Given this list of marker genes Slc47a1, Slc47a2, Slc22a1, Atp13a3, Slc22a2, here is a description of the gene set: species: Mus musculus Mouse Gene Set: GOMF_PUTRESCINE_TRANSMEMBRANE_TRANSPORTER_ACTIVITY Enables the transfer of putrescine from one side of a membrane to the other. Putrescine is 1,4-diaminobutane, the polyamine formed by decarboxylation of ornithine and the metabolic precursor of spermidine and spermine.